The following is a description of a gene set: species: Mus musculus Mouse Gene Set: GOMF_PHOSPHATIDYLCHOLINE_STEROL_O_ACYLTRANSFERASE_ACTIVATOR_ACTIVITY Binds to and increases the activity of phosphatidylcholine-sterol O-acyltransferase., and this is the list of marker genes: Apoe, Apoa2, Apoa5, Apoa4, Apoa1